The following is a description of a gene set: Enables the transmembrane transfer of an ion by a channel that opens when a specific extracellular inhibitory ligand has been bound by the channel complex or one of its constituent parts. Inhibitory ligands, such as GABA or glycine, open chloride-selective channels. studied in species Mus musculus Mouse Gene Set: GOMF_INHIBITORY_EXTRACELLULAR_LIGAND_GATED_MONOATOMIC_ION_CHANNEL_ACTIVITY, and this is the list of marker genes: Glra4, Gabrb2, Glra3, Glra1, Chrm5, Glra2, Gabra6, Glrb